The following is a description of a gene set: species: Homo sapiens The regrowth of cardiac muscle tissue to repair injured or damaged muscle fibers in the postnatal stage. Human Gene Set: GOBP_CARDIAC_MUSCLE_TISSUE_REGENERATION, and this is the list of marker genes: ERBB4, RUNX1, CDKN1A, YAP1 (Yes1 associated transcriptional regulator), GATA4, MIR199A1, MIR590, CDKN1B